The following is a description of a gene set: from publication Nurieva RI, Chung Y, Hwang D, Yang XO, Kang HS, Ma L, Wang YH, Watowich SS, Jetten AM, Tian Q, Dong C (PMID 18599325) Human Gene Set: GSE11924_TH1_VS_TH2_CD4_TCELL_UP species: Homo sapiens Genes up-regulated in comparison of Th1 cells versus Th2 cells. After activation, CD4+ helper T (Th) cells differentiate into distinct effector subsets. Although chemokine (C-X-C motif) receptor 5-expressing T follicular helper (Tfh) cells are important in humoral immunity, their developmental regulation is unclear. Here we show that Tfh cells had a distinct gene expression profile and developed in vivo independently of the Th1 or Th2 cell lineages. Tfh cell generation was regulated by ICOS ligand (ICOSL) expressed on B cells and was dependent on interleukin-21 (IL-21), IL-6, and signal transducer and activator of transcription 3. However, unlike Th17 cells, differentiation of Tfh cells did not require transforming growth factor b (TGF-b) or Th17-specific orphan nuclear receptors RORa and RORg in vivo. Finally, naive T cells activated in vitro in the presence of IL-21 but not TGF-b signaling preferentially acquired Tfh gene expression and promoted germinal-center reactions in vivo. This study thus demonstrates that Tfh is a distinct Th cell lineage., and this is the list of marker genes: SREK1, USF3, SELP (NCBI Gene Id 6403), KCNA4, GCSH, MIB1, BAG6, GFRA2, HSPBP1, MPP1, SCARF1, RGS3, POLDIP2, FNIP2, PRDM5, RUNX2, RPP40, NOP56 (NCBI Gene Id 10528), NTAN1, AKR1B1, C19orf44, UTP25, DCLK1, NXPE4 (neurexophilin and PC-esterase domain family member 4), WDR27, CACNG4, PAQR6, SWT1, GAN (gigaxonin), MTA2, ZNF473, ASPN, ACSL6, CCNK (cyclin K), DCAKD, DGKE, IQCG, NELFA, KIAA1549, SLC25A4, ATG7, THOP1, STARD10, UBE2B, ARHGAP9, CFAP54, CDH15, TAF5L, HSPA4L, COL2A1, MYO19, TXLNB, FAAP100, PSRC1, RCN2, POU2F1, RSPH6A, FCSK, PPP2R5D, CRLF3, DDX41, BRPF3 (NCBI Gene Id 27154), CRTAM, RASAL1, NUP214, SNRNP27 (small nuclear ribonucleoprotein U4/U6.U5 subunit 27), KAT2A, FRAT2, NAPRT, SLC27A1, RNF38, TAGLN2, GLYAT, NR0B2, PTPMT1, SGK3, MSI1, MRPS21, ZSCAN10, COX6B2, POLR3F, AIDA, MAP3K7, CPA5, MRPL30, PKNOX1, PTGDR2, PDCD7, MFNG, SERPINB9, C19orf38, PRKAR2A, CCT2, PPP1R8, RNF112, GNB2, C1orf159, SMYD3, SNX27, C1orf21, LMO3, NEFH, PABPN1L, CDK14, RPS27L, BRMS1, HSPA8, CHKA, AARS2, MRPS15, YTHDC2, RIN3, QTRT1, JADE2, IPO9, SLC6A5, ICAM2, PNMT, HSD17B2, C1QL2, KLC3, ODC1, MCM9, NOC4L, ZFPM1, GFOD1, UHRF2, TFDP1, AAGAB, VIRMA, PRMT7, JAKMIP3, LTA, RBAK, DONSON, ARL6IP4, GCH1, FHL2, TENT4A, EXOC7, GTF2F2 (general transcription factor IIF subunit 2), LAT, EEFSEC, BST2, MMP3, ISY1, TGM6, HEG1, DENND6A, MRPL16, BOC, METTL22, MDP1, DLK2, C1orf131, GBP4, CHRM3, NKG7, EFEMP2, FAM221B, S100A14, ASPG, CARD6, CORO1C, AAAS, LTK, C11orf52, ARMT1, GNPTAB, PPA2 (NCBI Gene Id 92033), FREY1, BEND4, ABHD8, INTS2, CASC3, IFITM10, MADD, BAX, CARD10, TMPRSS2, NOC2L, THOC5, MFAP3, OXA1L, TRIM8, PRPF4, SMG7, DGKD, MEF2D, USP18, CBX6, RAD23B, GREB1, NUDT9, UBQLN4, SEC24B, NSUN4, PPM1J (protein phosphatase, Mg2+/Mn2+ dependent 1J), CX3CL1, HOMER1